Given this list of marker genes SLC31A1, GJA1, PIK3CA (phosphatidylinositol-4,5-bisphosphate 3-kinase catalytic subunit alpha), FGF13, AKAP6, CAV3, CDH2, SCN1A, AHNAK, FLCN, ANK2, RAP2C, TMEM65, NECTIN2, YWHAH, BLOC1S6, OBSL1, TJP2, GJA5, PKP2 (plakophilin 2), CTNNA1, DES, CADM4 (cell adhesion molecule 4), VAMP5, NRAP, SPTBN4, CTNNB1 (catenin beta 1), DLG1, NECTIN3, ATP1B1, ITGB1, VCL, FLOT2, PKP4, JAM2, SCRIB, ATP1A2, TIAM1, ATP2A2, PCDH9, RANGRF, CXADR (CXADR Ig-like cell adhesion molecule), JAM3, ACTN1, AJAP1, AFDN, SCN1B, GJC1, PGM5, NECTIN1, FXYD1, PAK1 (NCBI Gene Id 5058), FLOT1, FHOD1, SLC8A1, ANK3, RAP2B, DSG2, KCNJ2, MYH1, DSP, SLC2A1, CTNNA3, SCN5A, PCDHA10, ANKRD23, SCN4B, PECAM1 (platelet and endothelial cell adhesion molecule 1), OPALIN, DSC2, FGFRL1, KCNA5, BAIAP2L2, JUP, SLC9A1, here is a description of the gene set: Human Gene Set: GOCC_CELL_CELL_CONTACT_ZONE Extended zone of intimate apposition between two cells containing one or more types of intercellular junctions, e.g., the intercalated disk of muscle. species: Homo sapiens